Given this list of marker genes KCNE4, GJA5, ANK2, KCNQ1, KCNH6, KCNH2 (NCBI Gene Id 4027), KCNE1, ZMPSTE24, CACNA2D1, SNTA1, KCNE2, KCNE3, WDR1, SCN1B, NOS1AP, CASQ2, AKAP9, NOS1, MIR1-1, RNF207, KCNE5, CAV3, MIR133A1, SCN4B, SCN5A, here is a description of the gene set: species: Homo sapiens Human Gene Set: GOBP_REGULATION_OF_VENTRICULAR_CARDIAC_MUSCLE_CELL_MEMBRANE_REPOLARIZATION Any process that modulates the establishment or extent of a membrane potential in the polarizing direction towards the resting potential in a ventricular cardiomyocyte.